The following is a description of a gene set: studied in species Homo sapiens part of: Diseases of signal transduction by growth factor receptors and second messengers Reactome Pathway: PI3K/AKT Signaling in Cancer Class IA PI3K is a heterodimer of a p85 regulatory subunit (encoded by PIK3R1, PIK3R2 or PIK3R3) and a p110 catalytic subunit (encoded by PIK3CA, PIK3CB or PIK3CD). In the absence of activating signals, the regulatory subunit stabilizes the catalytic subunit while inhibiting its activity. The complex becomes activated when extracellular signals stimulate the phosphorylation of the cytoplasmic domains of transmembrane receptors or receptor-associated proteins. The p85 regulatory subunit binds phosphorylated motifs of activator proteins, which induces a conformational change that relieves p85-mediated inhibition of the p110 catalytic subunit and enables PI3K to phosphorylate PIP2 to form PIP3. The phosphoinositide kinase activity of PI3K is opposed by the phosphoinositide phosphatase activity of PTEN. <br><br>PIP3 acts as a messenger that recruits PDPK1 (PDK1) and AKT (AKT1, AKT2 or AKT3) to the plasma membrane. PDPK1 also possesses a low affinity for PIP2, so small amounts of PDPK1 are always present at the membrane. Binding of AKT to PIP3 induces a conformational change that enables TORC2 complex to phosphorylate AKT at a conserved serine residue (S473 in AKT1). Phosphorylation at the serine residue enables AKT to bind to PDPK1 and exposes a conserved threonine residue (T308) that is phosphorylated by PDPK1. AKT phosphorylated at both serine and threonine residues dissociates from the plasma membrane and acts as a serine/threonine kinase that phosphorylates a number of cytosolic and nuclear targets involved in regulation of cell metabolism, survival and gene expression. For a recent review, please refer to Manning and Cantley, 2007. <br> Signaling by PI3K/AKT is frequently constitutively activated in cancer. This activation can be via gain-of-function mutations in PI3KCA (encoding catalytic subunit p110alpha), PIK3R1 (encoding regulatory subunit p85alpha) and AKT1. The PI3K/AKT pathway can also be constitutively activated by loss-of-function mutations in tumor suppressor genes such as PTEN. <br> Gain-of-function mutations activate PI3K signaling by diverse mechanisms. Mutations affecting the helical domain of PIK3CA and mutations affecting nSH2 and iSH2 domains of PIK3R1 impair inhibitory interactions between these two subunits while preserving their association. Mutations in the catalytic domain of PIK3CA enable the kinase to achieve an active conformation. PI3K complexes with gain-of-function mutations therefore produce PIP3 and activate downstream AKT in the absence of growth factors. While AKT1 gene copy number, expression level and phosphorylation are often increased in cancer, only one low frequency point mutation has been repeatedly reported in cancer and functionally studied. This mutation represents a substitution of a glutamic acid residue with lysine at position 17 of AKT1, and acts by enabling AKT1 to bind PIP2. PIP2-bound AKT1 is phosphorylated by TORC2 complex and by PDPK1 that is always present at the plasma membrane, due to low affinity for PIP2. Therefore, E17K substitution abrogates the need for PI3K in AKT1 activation. <br> Loss-of-function mutations affecting the phosphatase domain of PTEN are frequently found in sporadic cancers, as well as in PTEN hamartoma tumor syndromes (PHTS). PTEN can also be inactivated by gene deletion or epigenetic silencing, or indirectly by overexpression of microRNAs that target PTEN mRNA. Cells with deficient PTEN function have increased levels of PIP3, and therefore increased AKT activity. For a recent review, please refer to Hollander et al. 2011.<br> Because of their clear involvement in human cancers, PI3K and AKT are targets of considerable interest in the development of small molecule inhibitors. Although none of the currently available inhibitors display preference for mutant variants of PIK3CA or AKT, several inhibitors targeting the wild-type kinases are undergoing clinical trials. These include dual PI3K/mTOR inhibitors, class I PI3K inhibitors, pan-PI3K inhibitors, and pan-AKT inhibitors. While none have yet been approved for clinical use, these agents show promise for future therapeutics. In addition, isoform-specific PI3K and AKT inhibitors are currently being developed, and may provide more specific treatments along with reduced side-effects. For a recent review, please refer to Liu et al. 2009., and this is the list of marker genes: KITLG, GRB2, SRC, PRR5, FYN, AKT2, BAD, PIK3R3, RAC2, FGF10, BDNF, FOXO4, FGFR1, FGF5, FGF19, NTF3, FGFR4, PDGFRA, PIK3R2, FGF7, GSK3B, CASP9, LCK, PIK3CD, NRG1, FOXO1, PIK3CA, ESR1, FGF20, FGF1, PDGFRB, HGF, HBEGF, NTF4, FGF8, NRG3, VAV1, PDGFA, NTRK2, MTOR, STRN, FLT3LG, PIK3R6, FGF18, PIK3CB, ERBB4, FGF16, BTC, MAPKAP1, TRAT1, ICOS, FGF23, CHUK, GAB1, TSC2, KIT, ERBB3, GAB2, CD86, ESR2, CDKN1A, NTRK3, PDGFB, CREB1, RPS6KB2, NR4A1, FRS2, FGF4, AKT1, EGFR, EPGN, IRS2, FGF22, RHOG, PIK3R5, FOXO6, FGF17, MET, AKT1S1, PTPN11 (protein tyrosine phosphatase non-receptor type 11), FGF9, PDPK1, IRS1, PIK3R1, NRG2, RAC1, FOXO3, PTEN, CD19, MLST8, FLT3 (fms related receptor tyrosine kinase 3), TGFA, GSK3A, FGF6, EREG, CD28, KL, PIK3AP1, ERBB2, MDM2, KLB, CD80, PIK3CG, NRG4, AKT3, FGF2, FGFR3, AREG, FGF3, EGF, FGFR2, CDKN1B, RICTOR